The following is a description of a gene set: Mouse Gene Set: GOMF_SULFUR_COMPOUND_TRANSMEMBRANE_TRANSPORTER_ACTIVITY species: Mus musculus Enables the transfer of a sulfur compound from one side of a membrane to the other., and this is the list of marker genes: Gja1, Slc19a3, Mfsd12, Slc43a2, Slc6a13, Slc26a2, Slc26a4, Slc25a10, Slc25a26, Slc19a2, Slc25a42, Abcc1, Slc1a1, Slc25a40, Abcd1, Slc47a2, Slc35b2, Slc25a12, Slc22a1, Slc35b3, Ucp2, Slc25a17, Slc25a39 (NCBI Gene Id 68066), Slc26a5, Abcc4, Slc36a1, Slc13a1, Slc26a9, Slc7a9, Slc25a19, Slc26a1, Abcc3, Slc25a47, Slc26a6, Slc6a6, Slc6a11, Slc26a3, Ralbp1, Slc22a2, Slc26a11, Slc27a1, Slc47a1, Slc13a3, Abcc2, Slc1a2, Slc33a1, Abcg2 (NCBI Gene Id 26357), Slc5a6, Slc25a16, Slc1a4, Slc16a6, Slc44a4, Ctns, Slc26a8, Slc25a13, Slc26a10, Abcc10, Slc13a4, Abcc5, Abcc6, Slc7a11, Abcd2, Slc26a7